The following is a description of a gene set: studied in species Homo sapiens Human Gene Set: GOBP_POSITIVE_REGULATION_OF_PROTEIN_EXIT_FROM_ENDOPLASMIC_RETICULUM Any process that activates or increases the frequency, rate or extent of directed movement of proteins from the endoplasmic reticulum., and this is the list of marker genes: CRYZL2P-SEC16B, EDEM2, TM9SF4, EDEM1, TMEM30A, CD81, SEC16B, SLC35D3, SLC51B, TMEM30B, SORL1, BCAP31